Given this list of marker genes IRF8, GATA1, S100A9, PAX5, HOXA4, TLX1, CD79A, CD40, REL, IKZF3, WNT2, NKX3-2, HMGB3, SPIB, TAL1, CXCR5, CD19, BCL11A, MMP13, here is a description of the gene set: from publication Shin DM, Shaffer DJ, Wang H, Roopenian DC, Morse HC 3rd (PMID 19010892) Aside from Myc-activating translocations characteristic of plasmacytomas (PCT), little is known about genetic factors and signaling pathways responsible for the development of spontaneous B-cell lineage lymphomas of mice. Here, we characterized the transcriptional profiles of PCT, centroblastic diffuse large B-cell lymphomas (CBL), and high-grade splenic marginal zone B-cell lymphoma (MZL++) using high-throughput quantitative reverse transcription-PCR. Expression profiles of CBL and MZL++ were strikingly similar and quite unlike that of PCT. Among the genes expressed at significantly higher levels by PCT were a number involved in NOTCH signaling, a finding supported by gene set enrichment analyses of microarray data. To investigate the importance of this pathway, NOTCH signaling was blocked in PCT cell lines by treatment with a gamma-secretase inhibitor (GSI) or transduction of a dominant-negative mutant of MAML1. These treatments resulted in reduced expression of NOTCH transcriptional targets in association with impaired proliferation and increased apoptosis. GSI treatment of transformed plasma cells in a primary PCT also induced apoptosis. These results integrate NOTCH activation with oncogenic signaling pathways downstream of translocated Myc in the pathogenesis of mouse PCT, two signaling pathways also implicated in development of human multiple myeloma and T-cell lymphoblastic lymphoma. studied in species Mus musculus Cluster 9 of genes distinguishing among different B lymphocyte neoplasms. Human Gene Set: SHIN_B_CELL_LYMPHOMA_CLUSTER_9